Given this list of marker genes EXOSC3, LARP7, EXOSC5, DKC1, EXOSC6, EXOSC2, EXOSC10, FBL (NCBI Gene Id 2091), RNF113B, PARN, EXOSC4, TENT4B, FBLL1, RNF113A, here is a description of the gene set: Any process involved in the conversion of a primary snoRNA family RNA transcript into a mature snoRNA (eukaryota) or sRNA (archaea). Human Gene Set: GOBP_SNO_S_RNA_PROCESSING species: Homo sapiens